Given this list of marker genes ACSM2A, CYP2D6, UGT2B7, ABCC3, UGT2B10, GLYAT, UGT3A2, BSG, CES1, UGT3A1, CYP2C8, UGT2B15, GLYATL3, UGT2A3, UGT2A2, SLC16A1, CYP3A4, GLYATL1, UGT1A1, SLCO2B1, ACSM2B, UGT1A4, CYP2E1, UGT1A8, BCHE, ACSM5, CYP2C19, UGT1A7, UGT1A9 (NCBI Gene Id 54600), UGT2B11, UGT2B4, ABCC2, UGT1A6, UGT2B28, ACSM4 (acyl-CoA synthetase medium chain family member 4), UGT1A5, UGT2B17, UGT2A1, SLC22A7, GLYATL2, CES2, ALB, CYP2C9, UGT1A3, here is a description of the gene set: Human Gene Set: REACTOME_ASPIRIN_ADME Aspirin ADME species: Homo sapiens